The following is a description of a gene set: from publication Noushmehr H, Weisenberger DJ, Diefes K, Phillips HS, Pujara K, Berman BP, Pan F, Pelloski CE, Sulman EP, Bhat KP, Verhaak RG, Hoadley KA, Hayes DN, Perou CM, Schmidt HK, Ding L, Wilson RK, Van Den Berg D, Shen H, Bengtsson H, Neuvial P, Cope LM, Buckley J, Herman JG, Baylin SB, Laird PW, Aldape K, Cancer Genome Atlas Research Network (PMID 20399149) We have profiled promoter DNA methylation alterations in 272 glioblastoma tumors in the context of The Cancer Genome Atlas (TCGA). We found that a distinct subset of samples displays concerted hypermethylation at a large number of loci, indicating the existence of a glioma-CpG island methylator phenotype (G-CIMP). We validated G-CIMP in a set of non-TCGA glioblastomas and low-grade gliomas. G-CIMP tumors belong to the proneural subgroup, are more prevalent among lower-grade gliomas, display distinct copy-number alterations, and are tightly associated with IDH1 somatic mutations. Patients with G-CIMP tumors are younger at the time of diagnosis and experience significantly improved outcome. These findings identify G-CIMP as a distinct subset of human gliomas on molecular and clinical grounds. Genes with significantl germline mutation differences in proneural G-CIMP (a CpG island methylator phenotype) GBM (glyoblastoma multiforme) tumors. Human Gene Set: NOUSHMEHR_GBM_GERMLINE_MUTATED species: Homo sapiens, and this is the list of marker genes: PIP4K2A, CHAT, DGKZ, SOX13, ASCL2, KCNV2, CDH19, RBAKDN